Given this list of marker genes CACNA1A (NCBI Gene Id 773), ATP1A2, SLC35A2, SLC6A3, SLC1A3, ATP1A3, here is a description of the gene set: species: Homo sapiens Ocular flutter Human Gene Set: HP_OCULAR_FLUTTER Ocular flutter is an abnormal eye movement consisting of repetitive, irregular, involuntary bursts of horizontal saccades without an intersaccadic interval. It is generally superimposed on normal oculomotor behavior and its occurrence may be favored by various events, such as blinks, the triggering of normal saccades or optokinetic stimulation.